The following is a description of a gene set: Underdevelopment of the anterior pituitary gland. Anterior pituitary hypoplasia studied in species Homo sapiens Human Gene Set: HP_ANTERIOR_PITUITARY_HYPOPLASIA, and this is the list of marker genes: OTX2, ZSWIM6, MTHFR, GH1, PNPLA6, GLI2, PTDSS1, ARNT2, SLC30A7, ROBO1, PROKR2, VANGL2, FOXA2, FGFR1, RNPC3, OCA2, MAGEL2, PROP1, NDN, LHX4, TBX3, DMXL2, SIX6, HESX1, RBM28, IFT56, CDC42BPB, SOX2, POU1F1 (NCBI Gene Id 5449), NONO, SMAD2, SOX3, MADD, SNRPN, HID1, GHRHR, LHX3